The following is a description of a gene set: Genes showing decreasing expression in brown preadipocytes with increasing ability of the cells to differentiate. from publication Tseng YH, Butte AJ, Kokkotou E, Yechoor VK, Taniguchi CM, Kriauciunas KM, Cypess AM, Niinobe M, Yoshikawa K, Patti ME, Kahn CR (PMID 15895078) The insulin/IGF-1 (insulin-like growth factor 1) signalling pathway promotes adipocyte differentiation via complex signalling networks. Here, using microarray analysis of brown preadipocytes that are derived from wild-type and insulin receptor substrate (Irs) knockout animals that exhibit progressively impaired differentiation, we define genes/expressed-sequence tags whose expression in preadipocytes correlates with the ultimate ability of the cells to differentiate. Many of these genes, including preadipocyte factor-1 (Pref-1) and multiple members of the Wnt signalling pathway, are related to early adipogenic events. Necdin is also markedly increased in Irs knockout cells that cannot differentiate, and knockdown of necdin restores brown adipogenesis with downregulation of Pref-1 and Wnt10a expression. Insulin receptor substrate proteins regulate a necdin-E2F4 interaction that represses peroxisome-proliferator-activated receptor gamma (PPARgamma) transcription via a cyclic AMP response element binding protein (CREB)-dependent pathway. Together these define a key signalling network that is involved in brown preadipocyte determination. studied in species Mus musculus Human Gene Set: TSENG_ADIPOGENIC_POTENTIAL_DN, and this is the list of marker genes: TGFBI, GAS2, POPDC3, HLX, COL6A1, ART3, COL6A3, ENPP1, PPL, TSC22D1, TMEM185A, ADAM23, EBF3, PAX3, RAMP2, NRP1, B3GALNT1, SPARCL1, HSBP1, CST3, SNAI2, CAPN6, CMBL, CDKN2C, GHITM, IL6ST, NMB (NCBI Gene Id 4828), TSPAN6, COL4A2, FABP4, SESN1, DKK3, PLPP3, AOC3, LPAR1, SMS, SFRP2, IL1R1, THBD, GSTT1 (glutathione S-transferase theta 1), GJA1, PHKA2, FMO1, SIX1, ITIH2, EPHB6, RAB9A